The following is a description of a gene set: Pathway Definition from KEGG: FANCM+TOPBP1+MHF+FAAP24 -> ATR -> FAcore == FANCL+UBE2T -> FANCD2+FANCI+Ub Fanconi anemia pathway. Pathway ID: N01464. Pathway type: Reference. Pathway class: nt06508 Interstrand crosslink repair. species: Homo sapiens Human Gene Set: KEGG_MEDICUS_REFERENCE_FANCONI_ANEMIA_PATHWAY, and this is the list of marker genes: ATR, FANCF, CENPS, FANCG, FAAP100, FANCI, TOPBP1, UBB, FANCE, FANCM, UBE2T, FANCA, FANCB, FAAP20, FANCD2, FANCC, FAAP24, FANCL, CENPX